The following is a description of a gene set: Human Gene Set: HP_CRANIOFACIAL_OSTEOSCLEROSIS Craniofacial osteosclerosis studied in species Homo sapiens Abnormally increased density of craniofacial bone tissue., and this is the list of marker genes: AMER1, AP1S2, ANKH, TGFB1, DVL1, FAM111A, TBCE (tubulin folding cofactor E), PLEKHM1, SOST, LRP5, KL, CSF1R, TCIRG1, CLCN7, SLC39A14